Given this list of marker genes ATF4, MRTFA, PMF1, PAWR, AATF, NRL, DAPK3, JDP2, DDIT3, CRX, ATF2, here is a description of the gene set: Binding to a leucine zipper domain, a protein secondary structure exhibiting a periodic repetition of leucine residues at every seventh position over a distance covering eight helical turns. Human Gene Set: GOMF_LEUCINE_ZIPPER_DOMAIN_BINDING species: Homo sapiens